The following is a description of a gene set: Genes down-regulated in PaCa44 and CFPAC1 cells (pancreatic cancer) after treatment with decitabine, a DNA hypomethylating agent similar to azacitidine. Alteration of methylation status has been recognized as a possible epigenetic mechanism of selection during tumorigenesis in pancreatic cancer. This type of cancer is characterized by poor prognosis partly due to resistance to conventional drug treatments. We have used microarray technology to investigate the changes in global gene expression observed after treatment of different pancreatic cancer cell lines with the methylase inhibitor 5-aza-2'-deoxycytidine (5-aza-CdR). We have observed that this agent is able to inhibit to various degrees the growth of three pancreatic cancer cell lines. In particular, this inhibition was associated with induction of interferon (IFN)-related genes, as observed in other tumour types. Thus, expression of STAT1 seems to play a key role in the cellular response to treatment with the cytosine analogue. Moreover, we found increased p21(WAF1) and gadd45A expression to be associated with the efficacy of the treatment; this induction may correlate with activation of the IFN signalling pathway. Expression of the p16(INK) protein was also linked to the ability of cells to respond to 5-aza-CdR. Finally, genome-wide demethylation induced sensitization that significantly increased response to further treatment with various chemotherapy agents. Human Gene Set: MISSIAGLIA_REGULATED_BY_METHYLATION_DN from publication Missiaglia E, Donadelli M, Palmieri M, Crnogorac-Jurcevic T, Scarpa A, Lemoine NR (PMID 15637593) studied in species Homo sapiens, and this is the list of marker genes: FUT8, MDC1, NCAPD3, DEK, GMNN, MECOM, CAV1, RANBP1, PAICS, MDFI, RPA3, RCC1, CDT1, LIG1, RFC5, ARL6IP1, MICU1, PRC1, CDC6, MCM5, AARS1, NCAPH, SEMA3A, H2AZ2 (NCBI Gene Id 94239), GMPS, H2AZ1, SMC1A, HMGB1P10, SNRPA, HMGB2, DTYMK, LANCL1 (NCBI Gene Id 10314), PSIP1, SMC2, HNRNPA1, POLD2, RBMX, DHFR, HNRNPAB, BUB1B, TRIM28, CENPF, PRKDC, KIFC1, NEK2, MKI67, CSE1L, ARHGAP19, TYMS, ANP32B, CDKN3, PIR, RRM1, MSH6, SNRNP40, KIF23, ZWINT, HMGN2P9, AURKA, RAB26, POLD3, PCLAF, ILF3, CENPM, HMGB3, SMC4, STMN1, LMNB1, FOXM1, PCBP2 (NCBI Gene Id 5094), HNRNPL, CCNA2, UBE2C, KIAA0586, ZNF175, IFT20, FBL, FOSL1, PCDH7 (protocadherin 7), CENPE, CHEK1, CAD, HMGN2, NUSAP1, DUT, NRGN, EXOSC8, TK1, TMPO, SHMT1, CDKN2C, PRIM1, LBR, DLGAP5, KNTC1 (kinetochore associated 1), ACAT2, ESPL1 (NCBI Gene Id 9700), NDUFS3, ALYREF, CYP2J2, HDHD5, HAT1, RFC4, ITGB4, CDC45, CDK1, EZH2, HMGB1, ENOSF1, YES1, FASN, EBP, KIF22, CDC25C, RNASEH2A, DNMT1, LINC00667, MTFP1, DANCR, DCLRE1A, KIF14, SRSF3